The following is a description of a gene set: Human Gene Set: GOBP_POSITIVE_REGULATION_OF_PROTEIN_DEUBIQUITINATION Any process that activates or increases the frequency, rate or extent of protein deubiquitination. studied in species Homo sapiens, and this is the list of marker genes: NOP53, TANK, ZC3H12A, VCP, TNIP1